Given this list of marker genes MAOB, AOC3, GLUD1, MAOA, GLDC, LOX, IL4I1, ASPDH, AOC2, DAO (D-amino acid oxidase), AOC1, DDO, RNLS, LOXL3, VCAM1, GLUD2, LOXL1, PNPO, LOXL2, LOXL4, here is a description of the gene set: Human Gene Set: GOMF_OXIDOREDUCTASE_ACTIVITY_ACTING_ON_THE_CH_NH2_GROUP_OF_DONORS species: Homo sapiens Catalysis of an oxidation-reduction (redox) reaction in which a CH-NH2 group acts as a hydrogen or electron donor and reduces a hydrogen or electron acceptor.